The following is a description of a gene set: Human Gene Set: GNF2_UBE2I studied in species Homo sapiens Neighborhood of UBE2I ubiquitin-conjugating enzyme E2I (UBC9 homolog, yeast) in the GNF2 expression compendium Neighborhood of UBE2I, and this is the list of marker genes: PTBP1, RPL19, ZNF207, EIF3F, XRCC6, TRA2B, SRSF3, UXT, UBE2D2, PSMA7, EIF3K, POLR2G, RPS14, FBL, RPS16, POLR1D, UBXN1, ATP5MC2, UBA52, RTRAF, SERP1, EIF4A1, RPL8, RPL15, KARS1, EIF3D, LSM7, RPS15 (ribosomal protein S15), PSMA1, EPRS1, U2AF1, UBE2I, ATP5MG, SUMO2, EIF3L, RACK1, BTF3, SMNDC1, RBM4, HNRNPK, HNRNPF, KHDRBS1, PTMA, TRMT112